Given this list of marker genes KAT6B, NHLRC3, DAB2, KCNJ3, CLK4, MYL1, PITPNB, ICOS, PROZ, CPS1, MBOAT2, GAN (NCBI Gene Id 8139), FMO2, PNPLA1, NIPBL, L3MBTL1, SV2C, OCLN, MAP1B, PLAGL1, LSM14A, OSGEPL1, MAPK10, SLC4A5 (solute carrier family 4 member 5), MBNL1, RGS7, IL1RAP, GSAP, C1orf50, PM20D2, BICD1, STX11, CLDND1, ZNF25, VKORC1L1, MEAK7, CLEC4D, PDZD2, ZNF594, DCUN1D3, ESYT3, MDH1B, HNRNPA2B1, P3H2, MYOCD, TK2, SPZ1, GLRA2, LCP2 (lymphocyte cytosolic protein 2), here is a description of the gene set: Human Gene Set: MIR4513 Genes predicted to be targets of miRBase v22 microRNA hsa-miR-4513 in miRDB v6.0 with MirTarget v4 prediction scores > 80 (high confidence targets). from publication Chen Y, Wang X (PMID 31504780) studied in species Homo sapiens